The following is a description of a gene set: Human Gene Set: REACTOME_AMINE_LIGAND_BINDING_RECEPTORS species: Homo sapiens Amine ligand-binding receptors, and this is the list of marker genes: TAAR9, TAAR5, DRD5, HTR5A, HTR7, HTR1D, HTR2B, ADRB3, ADRA2A, CHRM3, CHRM5, DRD3, HRH4, HTR1E (5-hydroxytryptamine receptor 1E), HRH2 (histamine receptor H2), GPR143, HRH1, CHRM4, HTR1A, CHRM1, ADRA2B, ADRA2C, DRD2, DRD1, TAAR6, TAAR8, DRD4, ADRA1D, HTR1F, HTR4, ADRB2, HTR6, TAAR2, HRH3, HTR2C, CHRM2, ADRA1A, ADRB1, ADRA1B, TAAR1, HTR1B (5-hydroxytryptamine receptor 1B), HTR2A